Given this list of marker genes Gltp, Gltpd2, Mttp, Pltp, Cert1, Plekha8, Pitpnb, Cptp, here is a description of the gene set: studied in species Mus musculus Removes a sphingolipid from a membrane or a monolayer lipid particle, transports it through the aqueous phase while protected in a hydrophobic pocket, and brings it to an acceptor membrane or lipid particle. Mouse Gene Set: GOMF_SPHINGOLIPID_TRANSFER_ACTIVITY